The following is a description of a gene set: Binding to a neuropeptide receptor. species: Homo sapiens Human Gene Set: GOMF_NEUROPEPTIDE_RECEPTOR_BINDING, and this is the list of marker genes: PRLH, MRAP2, PPY, CCKBR, NPPA, TAC1, EDN3, GAL, HCRT, TAC3, KISS1, POMC, NTS, SPX, EDN2, CRH, UCN3, UCN, NPY, VIP, EDN1, NMU, GNAS, APELA, TAC4, ADCYAP1, GNAO1, PMCH, APLN, UCN2, NMB, SHANK1, QRFP, PYY, MRAP, PMCHL2, PYY3, AGRP, ASIP, GHRH